The following is a description of a gene set: Protrusion of the meninges through a defect of the skull or vertebral column. studied in species Homo sapiens Meningocele Human Gene Set: HP_MENINGOCELE, and this is the list of marker genes: GLI2, CSPP1, COL18A1, RIPPLY2, POMT1, WNT7A, SMO, POMT2, CPLANE1, CRPPA, SNRPB, DLL3, ARVCF, GP1BB, MESP2, COMT, SCAF4, HES7, VANGL1, ZSWIM6, TBX1, HIRA, B3GALNT2, UFD1, FKTN, RREB1, FKRP, GMPPB, PIK3CA, PTCH1, CEP290, TMEM216, KIAA0586, NOTCH3, LARGE1, SEC24C, SC5D, TMEM237, POMGNT1, JMJD1C, LFNG, GJA1, PAX3, INPP5E